Given this list of marker genes ALOX15, GPX1, GPX2, ALOXE3, ALOX12, ALOX12B, GPX4, here is a description of the gene set: studied in species Homo sapiens part of: Arachidonate metabolism The 12-eicosatetraenoic acids: 12-hydroperoxy-eicosatetraenoate (12-HpETE), 12-hydroxyeicosatetraenoate (12-HETE) and 12-oxo-eicosatetraenoate (12-oxoETE) are formed after the initial step of arachidonate oxidation by the arachidonate 12 and 15 lipoxygenases (ALOX12, ALOX12B and ALOX15 respectively). This part of the pathway is bifurcated at the level of 12S-hydroperoxy-eicosatetraenoate (12S-HpETE), which can either be reduced to 12S-hydro-eicosatetraenoate (12S-HETE) or converted to hepoxilins. Reactome Pathway: Synthesis of 12-eicosatetraenoic acid derivatives